The following is a description of a gene set: from publication Hägerstrand D, Hesselager G, Achterberg S, Wickenberg Bolin U, Kowanetz M, Kastemar M, Heldin CH, Isaksson A, Nistér M, Ostman A (PMID 16547494) Genes with the highest differential expression in primary tissue cultures of high grade glioma: responders vs non-responders to imatinib treatment. High-grade gliomas, including glioblastomas, are malignant brain tumors for which improved treatment is urgently needed. Genetic studies have demonstrated the existence of biologically distinct subsets. Preliminary studies have indicated that platelet-derived growth factor (PDGF) receptor signaling contributes to the growth of some of these tumors. In this study, human high-grade glioma primary cultures were analysed for sensitivity to treatment with the PDGF receptor inhibitor imatinib/Glivec/Gleevec/STI571. Six out of 15 cultures displayed more than 40% growth inhibition after imatinib treatment, whereas seven cultures showed less than 20% growth inhibition. In the sensitive cultures, apoptosis contributed to growth inhibition. Platelet-derived growth factor receptor status correlated with imatinib sensitivity. Supervised analyses of gene expression profiles and real-time PCR analyses identified expression of the chemokine CXCL12/SDF-1 (stromal cell-derived factor 1) as a predictor of imatinib sensitivity. Exogenous addition of CXCL12 to imatinib-insensitive cultures conferred some imatinib sensitivity. Finally, coregulation of CXCL12 and PDGF alpha-receptor was observed in glioblastoma biopsies. We have thus defined the characteristics of a novel imatinib-sensitive subset of glioma cultures, and provided evidence for a functional relationship between imatinib sensitivity and chemokine signaling. These findings will assist in the design and evaluation of clinical trials exploring therapeutic effects of imatinib on malignant brain tumors. species: Homo sapiens Human Gene Set: HAEGERSTRAND_RESPONSE_TO_IMATINIB, and this is the list of marker genes: CREB1, ITGA8, PDGFRB, PTGFR, CXCL12, FXYD1, AEBP1, COL1A1, COL15A1